Given this list of marker genes ARHGDIA (NCBI Gene Id 396), RBL2, PIK3R2 (NCBI Gene Id 5296), IGFBP2, ADORA1, CDH3, CUX1, IER3, CASK, ITGB6, BAX, NR2F6, NFIX, APP, AMPH, CAPNS1, ITGA5, MCM4, POLD1, NFKB1, ZNF91, NF2, BNIP3, DNPH1, COMT, GNAS, FOS, HMGA1, JUND, ID1, LCAT, CCNA2, DAPK1, here is a description of the gene set: Oxidative stress genes down-regulated in ARPE-19 cells (retinal pigmented epithelium) in response to HNE, tBH and H2O2. Human Gene Set: WEIGEL_OXIDATIVE_STRESS_RESPONSE Oxidative stress plays a key role in aging diseases of the posterior pole of the eye such as age-related macular degeneration. The oxidative stress response of in vitro RPE cells has been studied for a small number of genes. However, a comprehensive transcriptional response has yet to be elucidated. The purpose of this study was to determine if the transcription of a common set of genes is altered by exposure of ARPE-19 cells to three major generators of oxidative stress, hydrogen peroxide (H2O2), 4-hydroxynonenal (HNE), and tert-butylhydroperoxide (tBH). As expected, a common response was observed that included genes differentially regulated by all three treatments. Of these, only one gene was upregulated, and only by one oxidant, while all other responses were downregulation. The majority of these genes fell into five functional categories: apoptosis, cell cycle regulation, cell-cell communication, signal transduction, and transcriptional regulation. Additionally, a large number of genes were differentially regulated by one oxidant only, including the majority of the conventional oxidative stress response genes present on the Clontech Human 1.2 microarray. This study raises questions regarding the generality of results that involve the use of a single oxidant and a single cell culture condition. studied in species Homo sapiens from publication Weigel AL, Handa JT, Hjelmeland LM (PMID 12419474)